Given this list of marker genes THRB, THRA, CRYM, CTSH, ALDH1A3, here is a description of the gene set: Binding to thyroxine (T4) or triiodothyronine (T3), tyrosine-based hormones produced by the thyroid gland. species: Homo sapiens Human Gene Set: GOMF_THYROID_HORMONE_BINDING